Given this list of marker genes Egfl7, Angptl3, Cdh5, Rhob, Vegfa, Plxnd1 (NCBI Gene Id 67784), Itgav, Nr2f2, here is a description of the gene set: species: Mus musculus from publication Rankin EB, Rha J, Unger TL, Wu CH, Shutt HP, Johnson RS, Simon MC, Keith B, Haase VH (PMID 18490920) Mouse Gene Set: RANKIN_ANGIOGENIC_TARGETS_OF_VHL_HIF2A_DN Angiogenic genes down-regulated in hepatocytes after knockout of VHL and HIF2A. The von Hippel-Lindau tumor suppressor pVHL regulates the stability of hypoxia-inducible factors (HIF)-1 and -2, oxygen-sensitive basic helix-loop-helix transcription factors, which mediate the hypoxic induction of angiogenic growth factors such as vascular endothelial growth factor. Loss of pVHL function results in constitutive activation of HIF-1 and HIF-2 and is associated with the development of highly vascularized tumors in multiple organs. We have used a conditional gene-targeting approach to investigate the relative contributions of HIF-1 and HIF-2 to VHL-associated vascular tumorigenesis in a mouse model of liver hemangiomas. Here we demonstrate genetically that conditional inactivation of HIF-2alpha suppressed the development of VHL-associated liver hemangiomas and that angiogenic gene expression in hepatocytes is predominantly regulated by HIF-2 and not by HIF-1. These findings suggest that HIF-2 is the dominant HIF in the pathogenesis of VHL-associated vascular tumors and that pharmacologic targeting of HIF-2 may be an effective strategy for their treatment.